The following is a description of a gene set: from publication Ramilo O, Allman W, Chung W, Mejias A, Ardura M, Glaser C, Wittkowski KM, Piqueras B, Banchereau J, Palucka AK, Chaussabel D (PMID 17105821) Each infectious agent represents a unique combination of pathogen-associated molecular patterns that interact with specific pattern-recognition receptors expressed on immune cells. Therefore, we surmised that the blood immune cells of individuals with different infections might bear discriminative transcriptional signatures. Gene expression profiles were obtained for 131 peripheral blood samples from pediatric patients with acute infections caused by influenza A virus, Gram-negative (Escherichia coli) or Gram-positive (Staphylococcus aureus and Streptococcus pneumoniae) bacteria. Thirty-five genes were identified that best discriminate patients with influenza A virus infection from patients with either E coli or S pneumoniae infection. These genes classified with 95% accuracy (35 of 37 samples) an independent set of patients with either influenza A, E coli, or S pneumoniae infection. A different signature discriminated patients with E coli versus S aureus infections with 85% accuracy (34 of 40). Furthermore, distinctive gene expression patterns were observed in patients presenting with respiratory infections of different etiologies. Thus, microarray analyses of patient peripheral blood leukocytes might assist in the differential diagnosis of infectious diseases. Genes down-regulated in comparison of peripheral blood mononuclear cells (PBMC) from healthy donors versus PBMC from patients with acute S. aureus infection. species: Homo sapiens Human Gene Set: GSE6269_FLU_VS_STAPH_AUREUS_INF_PBMC_DN, and this is the list of marker genes: P2RY2 (NCBI Gene Id 5029), TLR2, FLVCR2, TOLLIP, FSCN1, RNF19B, MAX, ADIPOR1, DUSP3, SPI1, S100A11P1, HS3ST3B1, PELI2, NPC2, GNA15, SOCS3, ASGR2, GRINA, LAMA4, MICAL2, ELF4, SIRPA, CD93, H1-0, FADS1, CTSD, SDCBP, FPR1, SERPINB1, S100A10, RRAGD, RIOK3, CTSB, IL1RN, TOM1, SREBF2 (sterol regulatory element binding transcription factor 2), TKT, FUT4, PHC2, SIRPAP1, CPD, ZFAND5, TFEC, EIF1, ARF1, SUMO3, ABCC6, HIF1A, CLEC7A, ZYX, ZDHHC3, NFIL3, CYBRD1, APLP2, PLP2, LYZ, MPP1 (NCBI Gene Id 4354), SORT1, SLC22A4, CKAP4, NRG1 (neuregulin 1), SLC15A3, PLD3, SAMD4A, RAB20 (RAB20, member RAS oncogene family), RXRA, LEPROT, FXYD6, SERPINA1, PPT1, ICAM1, PPP1R15A, PLAUR, SMARCD3, GAPDH, NPL, CREG1, DEFA1 (NCBI Gene Id 504182), GAS7, RHEBP1, GK, ADM, ELOA, NINJ1, TIMP1, IFI30, CEBPB, ACSL1, S100A9, SLC11A1, TFE3, MXD1, ARF4, C2, VAMP3, NOD2, QPCT, S100A8, PGD, DSE, STEAP3, BLVRB, MARCHF2, CDKN1A, ANPEP, ADAM9, EGR1, CDKN2D, VIM, FCN1, DAZAP2, LAMP2, TIMP2, KLF10, CD36, PRRG4, NAPA, PLBD1, CREB5, VCAN, BST1, CSF2RA, GRN, BNIP3L, SOD2, STAB1, IFNGR1 (interferon gamma receptor 1), MIR22HG, SLCO3A1, CTIF, CD63, GNG10, RAB1A, IL1RAP, RHOA, FTH1, LILRA5 (NCBI Gene Id 95091), GLUL, WLS, RNASE2, EMILIN2, VNN2, PLIN3, CDC42EP3, P2RX4, IMPA2, HPSE, DYSF, SBNO2, LGALS3, LAPTM4A, CSF3R, NEU1, RNF130, SEMA6B, PLEK, RAB5IF, NCF4, DHCR7, SRGN, FCGR1A, RTN2, PPIF, FHL3, TLE3, MBOAT7, MACROH2A1 (macroH2A.1 histone)